The following is a description of a gene set: Human Gene Set: HP_DEVIATION_OF_THE_HALLUX species: Homo sapiens Displacement of the big toe from its normal position. Deviation of the hallux, and this is the list of marker genes: PYCR1, TP63, EP300, ZEB2, CDKL5, LIMK1 (LIM domain kinase 1), SMARCA2, CLIP2, ACVR1, USP7, ERF, HOXD13, TBC1D2B, SLC16A2, AEBP1, ZMIZ1, MLXIPL, CHST3, BMP2, STX1A, KCNN3, DYRK1A, COL1A1, BUD23, YY1, TCF12, GNPNAT1, CHST11, PSMB8, B3GALT6, FHL1, FGF9, GTF2I, CREBBP, COL1A2, USP9X, VPS37D, ITCH, SF3B4, FGFR2, H4C9, METTL27, KCNH1, AKT1, PRDM5, B3GAT3, BMPR1B, FGFR1, NUP107, TMEM270, SRY, GBA1 (glucosylceramidase beta 1), NCF1, FGFR3, SLC29A3, RBBP8, ERMARD, DNAJC30, ATL3, EIF4H, PCDHGC4, TBL2, TWIST1, HEATR3, ATP6V1B2, GTF2IRD2, FKBP6, IL11RA, KDM5A, SPTAN1, NFIX, GDF5, ZNF469, EHMT1, HOXA13, SCAF4, ELN, RFC2, SCARF2, KAT6A, ZNF668, CWC27, ZFX, SOX9, C2CD3, TTI2, NONO, MYH3, BAZ1B, GTF2IRD1